The following is a description of a gene set: Any process that modulates the frequency, rate or extent of the formation and development of a tooth or teeth. studied in species Mus musculus Mouse Gene Set: GOBP_REGULATION_OF_ODONTOGENESIS, and this is the list of marker genes: Edn1, Pax9 (NCBI Gene Id 18511), Runx2, Tnfrsf11b, Cd34, Shh, Apc, Ift88, Bmp4, Csf1, Bmp2, Rspo2, Apcdd1, Prkcb, Wnt10a, Dicer1 (dicer 1, ribonuclease type III), Sp6, Msx1, Dmrt3, Ngfr, Ednra, Mir875, Fgf8, Tgfb1 (NCBI Gene Id 21803)